The following is a description of a gene set: species: Homo sapiens Reactome Pathway: IRAK4 deficiency (TLR5) part of: Diseases associated with the TLR signaling cascade Toll like receptor 5 (TLR5) specifically recognizes bacterial infection through binding of flagellin from pathogenic bacteria. Upon ligand binding, TLR5 dimers recruit MyD88 through their TIR domains. Then, MyD88 oligomerizes via its death domain (DD) and TIR domain and interacts with the interleukin-1 receptor-associated kinases (IRAKs) to form the Myddosome complex (MyD88:IRAK4:IRAK1/2) (Motshwene PG et al. 2009; Lin SC et al. 2010). The Myddosome complex transmits the signal leading to activation of transcription factors such as nuclear factor-kappaB (NFkB) and activator protein 1 (AP1). Studies have identified patients with autosomal recessive (AR) form of IRAK4 deficiency, a health condition with clinical manifestation in infancy or early childhood, that predisposes affected patients to recurrent pyogenic bacterial infection (e.g., Streptococcus pneumoniae and Staphylococcus aureus) (Picard C et al. 2003; Ku CL et al. 2007; Picard C et al. 2010; Picard C et al. 2011). Leukocytes derived from IRAK4-deficient patients display a lack of production of inflammatory cytokines such as TNF alpha, IL-6 and IL-1beta or a lack of CD62 ligand (CD62L) shedding from granulocytes following activation with flagellin, the TLR5 agonist (Picard C et al. 2003; McDonald DR et al. 2006; Ku CL et al. 2007). Patients with AR IRAK4 deficiency were found to bear homozygous or compound heterozygous mutations in the IRAK4 gene (Picard C et al. 2003; Ku CL et al. 2007; McDonald DR et al. 2006). Here we describe selective mutations, that have been functionally characterized. Cell-based assays as well as in vitro protein-interaction analyses with IRAK4 variants showed that the loss-of-function of defective IRAK4 can be caused by either an abolished protein production as a result of nonsense mutations (e.g.,Q293* and E402*) or an impaired interaction with MyD88 due to missense mutations (e.g., R12C) (Ku CL et al. 2007; Yamamoto T et al. 2014).<p>IRAK4 mediates immune responses downstream of all TLRs except for TLR3. We did not include defective TLR7, TLR8 and TLR9 signaling events, which are stimulated by nucleic acids upon viral infections, although studies using patients-derived blood cells have showed abolished cytokines production by peripheral blood mononuclear cells (PBMCs) and lack of CD62 ligand (CD62L) shedding from granulocytes in response to TLR7-9 agonists, i.e.,3M-13 (TLR7), 3M-2 (TLR8), R848 (TLR7 and 8) and CpG (TLR9) (McDonald DR et al. 2006; von Bernuth H et al. 2006; Ku CL et al. 2007). In addition to TLR-NFkB signaling axis the endosomic TLR7-9 activate IFN-alpha/beta and IFN-gamma responses, which have been also impaired in IRAK4-deficient PBMC (Yang K et al. 2005). However, IFN-alpha/beta and IFN-gamma production in response to 9 of 11 viruses tested was normal or weakly affected in IRAK-4-deficient blood cells, suggesting that IRAK-4-deficient patients may control viral infections by TLR7-9-independent production of IFNs (Yang K et al. 2005). So it is not yet possible to annotate a definitive molecular pathway between IRAK-4 deficiency and changes in TLR7-9 signaling., and this is the list of marker genes: MYD88, TLR10, TLR5, fliC, IRAK4